The following is a description of a gene set: Human Gene Set: GOCC_SIGNAL_RECOGNITION_PARTICLE A complex of protein and RNA which facilitates translocation of proteins across membranes. species: Homo sapiens, and this is the list of marker genes: SRP14, BHLHE40-AS1 (NCBI Gene Id 100509862), TTC9-DT, SRP19, RN7SL2, SRP68, SRP72, RN7SL1, GJD2-DT, SRP9, RN7SL3, SRP54, SNAP25-AS1, ENSG00000283175